The following is a description of a gene set: species: Homo sapiens Active immunotherapy is a promising strategy for anti-angiogenic cancer therapy. Recently, we have reported that a vaccine using human umbilical vein endothelial cells (HUVECs) induced specific anti-endothelial immune responses in the most of immunized patients, and resulted in tumor regression in some patients with recurrent malignant brain tumors, whereas not in colorectal cancer patients. In this study, we hypothesized that non-hypoxic perivascular tumor associated macrophages (TAMs) in colorectal cancer, but not in glioblastoma, might negatively alter the therapeutic efficacy of anti-angiogenic active immunotherapy. To test this hypothesis, we examined global gene expression profiles of non-hypoxic macrophages stimulated in vitro by soluble factors released from tumor cells of human glioblastoma U-87MG (‘brain TAMs’) or colorectal adenocarcinoma HT-29 (‘colon TAMs’). Genes up-regulated in macrophages: control versus tumor associated. Human Gene Set: GSE18804_SPLEEN_MACROPHAGE_VS_TUMORAL_MACROPHAGE_UP, and this is the list of marker genes: MIEN1, TOP2A, CNRIP1, UBE2E3, PIKFYVE, NFE2L2, SAP130, WDR36 (NCBI Gene Id 574015), NLRP11, C1GALT1, KCNN2, BTBD7, MOAP1, MT1HL1, FMNL2, ZC3H8, USE1, FOXO4, GLI3, NABP1, MSL1, IER3, CMSS1, BUB1, NDRG2, NEK2, ZNF365, WDSUB1, CALCA, LYSMD4, DHRS2, SPOCK1, TRAPPC6B (trafficking protein particle complex subunit 6B), ZFP62, SNHG20, MRPS24, RPL6, PLAAT3, DCAF4, LASP1, BAG5, RHOU, DBF4, PCGF5, HYCC2, PSMA3-AS1, TTLL7, TFPI2, SAMD5, ARMCX5, MAPK9, NR3C1, CCN3 (NCBI Gene Id 4856), MT1X, ATG14, PAPOLA, ZNF559, PIN4, GAS2L3 (NCBI Gene Id 283431), TMEM200C, SGO2, C10orf95-AS1, PHLDA2, NDUFA4, MAIP1, SYTL5, MT2A, CDK12, GPN1, SEPTIN7, FGF13, FAM133B, CAMK1D, CXCL8, CALHM5, RBM26, GHR, EDIL3, RALA, CLDN12, TNFAIP3, CDK6, AMIGO2, GPD2, MT1F, DNER, OPTN, FIBIN (fin bud initiation factor homolog), SKA2, ANXA2P2, TRIP12, EDNRB, BECN1, TWIST1, DDHD1, TMSB15B, COG6, GID8, DLEU2, STAT1 (NCBI Gene Id 6772), ISL1, RIF1, RAMP1, NMU, GLCCI1, ZFR, SCIN, USP24, CNTN1, PRRX1, KLHL5, LINC00460, XRCC5, TAC1, AKR1C1, CIPC, KHNYN, CEBPZ, ACADL, CTC1, SLC35D2, GAL, SEPHS1, GLOD4, LYPD1, KLF10, TMEM185A, TIMM9, AJUBA, SLIRP, BASP1, PSMB9, HS6ST3, FN1, FKBP11, TCEAL7, ACTR10, GPNMB, FAM111A, ZNF107, MAX, GOLGA4, STRADB, CSNK1A1, GCC2 (NCBI Gene Id 9648), RCOR1, PTCHD1, ABCG2, ANXA2 (annexin A2), PLEKHB2 (NCBI Gene Id 55041), ANXA3, ID2, CXCL6, MGAT2 (alpha-1,6-mannosyl-glycoprotein 2-beta-N-acetylglucosaminyltransferase), ETS2, NDUFS7, PAX3, LRRN1, KIF4A, ARHGEF18, ZFTA, SPC24, IL6R, SACS, RPL36AL, SMAD7, IFT52, OXA1L, TMEM200A, PLEK2, ZNF621, ID1, FRA10AC1, PSME2, SRSF1, CHN1, PROM1, USP42, RTN1, GPAM (glycerol-3-phosphate acyltransferase, mitochondrial), UBE2QL1, PRKRA, MT1H, RPS4X, ABCB7, TNFAIP1, PSME1, SLC2A3, MALSU1, NEDD4L, TAF4, PAPLN, GPR85, GNG2, TRIM10, BMP2, RBM12, AMPH, CCDC51